Given this list of marker genes ZNF394, APOL3, ARHGAP45, STK10, TNFRSF8, CFD, NADK (NCBI Gene Id 65220), EVI2A, FCGR2A, PPM1F, MCL1, IKBKB (NCBI Gene Id 3551), ING1, PKN2, ADGRE1, SEMA4A, AMPD2, ZNF266, RBM5, CDKN2D, CSTA, JARID2, LPCAT1, ARHGAP4, NBEAL2, MTMR11, CFP, TOE1, RBM6, HMGB2, UBA3, GPSM3, MTMR3, NUP50, FNBP4, SPSB3, SAP30BP, CHD1, CHKB, CRISPLD2, RSRP1, SIPA1L1, ICAM2, CNOT2, CTBP2, TESC, ZC3H11A, SORL1, WDR48, AGTPBP1, MTSS1, PELI1, PIK3CD, IL10RA, TET3, TUT7, ITGA4, CASP1, SPEN (NCBI Gene Id 348488), LIMD2, NLRP3, IER2, KLF2, FRAT1, PHF21A (NCBI Gene Id 51317), SMARCD3, KDM7A, NOTCH2NLA, CD244, GABPB1-IT1, DUSP1, S100A12, LYST, PLP2, SP110, SELL, GCH1, MID1IP1, KDM4B, KIAA0040, TNFRSF1B, KMT2A (lysine methyltransferase 2A), KLF13, S100A9, ARGLU1, TGIF2, SECISBP2, TRIM22 (NCBI Gene Id 10346), CLK1, NFE2, NCF1C, TNRC6B, CIDEB, RESF1, BLTP1, CDK5RAP3, SRSF5, FAU, S1PR4, C15orf39, KLF4, IRAK3, DUSP6, SMPDL3A, ADAP1, IPCEF1, NOD2, PCF11, ARID3A, MYO1F, LILRA1, PELI2, EXT1, KLF6, DENND3, USP15, IL6R, DUSP22, BTN3A3, HELZ, CNTRL, CRLF3 (NCBI Gene Id 51379), GTPBP1, OGA, RGS14, PDP1, CLK4, CCNG2, SATB1, MX2, NDE1, TPPP3, AKAP17A, ING3, JUNB, CD93, RXRB, PLAC8, VNN2, ZFP36, HSPA6, INPP5A, SETX, NHERF1, TSC22D3, TNFSF10, HSD17B11, IFITM2, CSF3R, C11orf21, RGS2, SEMA4D (semaphorin 4D), MKNK2, DAPP1, PSMB10, ARHGAP26, CPVL, IRF7, SIGIRR, IL15, F5, ZBTB18, FYB1, CEBPD, ICAM3, RAP1GAP2, NEDD9, PDCD4, CD1D, DAZAP2, CBFA2T3, SIK3, UNC119, APOBEC3A (apolipoprotein B mRNA editing enzyme catalytic subunit 3A), LINC00623, SYF2, WAS, LYN, NOTCH2, EHBP1L1, CX3CR1, NLRP1, EPM2AIP1, DELE1, TRAF3IP3, EZH1, LAT2, BTN3A1, GADD45B, CRBN, PNISR, ASGR2, MIS18BP1, IL16, ULK1, PTPRC, NXF1, RIPOR2, LILRA3, here is a description of the gene set: Human Gene Set: GSE22886_DAY0_VS_DAY7_MONOCYTE_IN_CULTURE_UP species: Homo sapiens from publication Abbas AR, Baldwin D, Ma Y, Ouyang W, Gurney A, Martin F, Fong S, van Lookeren Campagne M, Godowski P, Williams PM, Chan AC, Clark HF (PMID 15789058) Immune cell-specific expression is one indication of the importance of a gene's role in the immune response. In order to identify such patterns, we set out to broadly profile gene expression in a variety of immune cells. Genes up-regulated in comparison of monocytes cultured for 0 days versus those cultured for 7 days.